Given this list of marker genes IL17RD, HTRA2, IL17RC, IKZF1, PODXL, PARK7, PROK2, PROKR2, GNRHR, GNRH1, FGFR1, CLEC7A, NDNF, VPS13C, FZD2, HESX1, SEMA3A, HLA-DRB1, WDR11, KISS1, ZNF365, PINK1, FSHB, TACR3, RTN2, SNCA, UCHL1, COQ2, FGF8, TRAF3IP2, MEN1, IL17F, CTSH (cathepsin H), AIP, KISS1R, DUSP6, TNFSF4, FGF17, IRF5, CCN2, LRRK2, CCR6, MOG, TAC3, CCDC141, UBAP1, HLA-DQB1, FEZF1, CAV1, P2RY11, ANOS1, FLRT3, ABCD1, CDH23, NSMF, SPRY4, DNAJC6, CHD7, IL17RA, HS6ST1, SYNJ1, DCC, NHLH2, HCRT, PRKN, SOX10, HLA-B, here is a description of the gene set: species: Homo sapiens Female sexual dysfunction A problem occurring during any phase of the female sexual response cycle that prevents the individual from experiencing satisfaction from the sexual activity Human Gene Set: HP_FEMALE_SEXUAL_DYSFUNCTION